The following is a description of a gene set: The chemical reactions and pathways resulting in the formation of any conjugated, water-soluble protein in which the covalently attached nonprotein group consists of a lipid or lipids. Human Gene Set: GOBP_LIPOPROTEIN_BIOSYNTHETIC_PROCESS species: Homo sapiens, and this is the list of marker genes: ZDHHC14, ZDHHC21, ZDHHC3, ZDHHC15, ZDHHC23, NMT1, APOE, PPM1B, APOA1, ZDHHC20, UGCG, CLIP3, SELENOK, ZDHHC9, APOBEC1, MBOAT4, LCAT, GLUL, IRGM, ZDHHC19, ZDHHC11, ZDHHC5 (NCBI Gene Id 25921), HHATL, ZDHHC7, ATG16L1 (autophagy related 16 like 1), ATG7, ZDHHC12, PPM1A, PORCN, ZDHHC17, ZDHHC2, GOLGA7, RABL3, RAB3GAP2, RAB3GAP1, ZDHHC8, ZDHHC18, SVIP, HHAT, APOB, ABCA1, ZDHHC6, ZDHHC16, PIK3C3, ZDHHC1, ZDHHC22, ALOX12B, DBI, NMT2